The following is a description of a gene set: Human Gene Set: GSE17721_PAM3CSK4_VS_CPG_16H_BMDC_UP Genes up-regulated in comparison of dendritic cells (DC) stimulated with Pam3Csk4 (TLR1/2 agonist) at 16 h versus DC cells stimulated with CpG DNA (TLR9 agonist) at 16 h. studied in species Homo sapiens from publication Amit I, Garber M, Chevrier N, Leite AP, Donner Y, Eisenhaure T, Guttman M, Grenier JK, Li W, Zuk O, Schubert LA, Birditt B, Shay T, Goren A, Zhang X, Smith Z, Deering R, McDonald RC, Cabili M, Bernstein BE, Rinn JL, Meissner A, Root DE, Hacohen N, Regev A (PMID 19729616) mouse primary BMDCs were stimulated with tlr ligands and gene expression changes were profiled on Affymetrix arrays, and this is the list of marker genes: PRG3, XRCC5, TSPAN13, RNF207, MBL2, ADD3, POFUT2, TMEM266, ALDH2 (NCBI Gene Id 217), SIGLEC7, SLC10A2, CACNG2, SLC44A1, RPL28, ADAM22, GC, IFT25, RAB27B, B3GALNT2, HSPA5, SAMD8, COX8A, ARHGAP21, LIMK2, ACP3, SCD, RMND5A, FAM167B, PTPRS, BMP7, DTNB, EID1 (EP300 interacting inhibitor of differentiation 1), SFXN1, KRT14, RTN3 (reticulon 3), ASCC1, SYNPR, CD1D, EHD1, PYGO2, HOXA5, PDE4B, CLEC14A, KMT2D, SHANK3, RNF7, PTGER2, EDAR, NTM, FPR2, NDST4, ATP6V0D1, TACC2, RNASET2, SHPRH, SFXN4, TSPAN12, RGL2, PTCH1, VN1R5, FAM118B, SRPRB, MRPL24, LTB4R, UBE4B, PYGM, ARGLU1, EXTL2, SLC3A2, DPH6, NEDD9, TRRAP, RAB7A, RPS4X, WASL, CPNE3, SPTBN1, RPS6KA1, HUS1, DHRS7B, ADIG, NOP2 (NOP2 nucleolar protein), LIMCH1, EMC2, ING1, GSPT2, ZHX1 (zinc fingers and homeoboxes 1), RNF103, TFB2M, CRISP2, FIBP, TMEM147, ANGEL2, ACVR1B, C14orf119, PRELID3B, OSR1, ITCH, FAM162A, PIGA, PCBP3, EGF (NCBI Gene Id 1950), SRM, FBN2, USP34, CASP2, GDI1 (GDP dissociation inhibitor 1), SREK1IP1 (NCBI Gene Id 285672), TNFAIP2, NUP160, ATAD2B, SLC35C1, SPATS2L, UQCC3, FDFT1, SLC44A2, CEBPZOS, TUG1, ABHD14A, NEAT1, URI1, NAA38, RAMP2 (receptor activity modifying protein 2), AICDA, MMP2, RNF181, SPRR2A, CALCRL (calcitonin receptor like receptor), CAV2 (caveolin 2), UCHL1, PTGER3, IFT57, IFNAR2 (interferon alpha and beta receptor subunit 2), CRELD1 (NCBI Gene Id 78987), CLEC5A, KIF1B, MOSPD2, TM2D1, EMP3, ABL1, FXYD6, AVPI1, FAM174A, BPNT2, ASB18, COL5A1, VSIG4, EIF3K, GPALPP1, ANAPC11, MICOS10, FBXO43, TTLL3, PGK2, ATP2A2 (ATPase sarcoplasmic/endoplasmic reticulum Ca2+ transporting 2), MT2A, FAM151A (NCBI Gene Id 338094), CIMIP2A, VPS37A, SLC25A29 (solute carrier family 25 member 29), ERLEC1, SLC11A1, GGH, SLC38A1 (NCBI Gene Id 81539), RUSF1, PDGFD, XPR1, UBA1, HMGCS1, TOP2B, RPL22L1, TCTE1, IER3IP1, COL4A5, MAN1A1 (mannosidase alpha class 1A member 1), ARMC1, PLS3, PRODH, EWSR1, TMEM63A, CERS5, ARFGAP3, PPIC, CRBN, NEDD4L, SEBOX, ALB, SRSF11, PRG4, MMP9, ING4, FKBPL, BTBD1, PROCR, LAMTOR4, PARG, ZC3H12C, RNF149, PTPRE, ZPBP